Given this list of marker genes MYO9A, FRMD4A, TCF15, FOXF1, NHERF1, CDC42, SIPA1L3, RAP2A, WNT5A, SHH, FAT1 (FAT atypical cadherin 1), TTC8, MSN, FBF1, PARD3, GOLPH3, CYTH3, HES5, EZR, ARF6, MYO18A, CYTH1, HES1, RHOA, IFT20, OPHN1, LAMA1, SH3BP1, FERMT1, CAMSAP3, FRMD4B, PTK7, SYNE4, here is a description of the gene set: Human Gene Set: GOBP_ESTABLISHMENT_OF_EPITHELIAL_CELL_POLARITY species: Homo sapiens The specification and formation of anisotropic intracellular organization of an epithelial cell.